The following is a description of a gene set: studied in species Mus musculus Any process that activates or increases the frequency, rate, or extent of a T-helper 1 type immune response. Mouse Gene Set: GOBP_POSITIVE_REGULATION_OF_T_HELPER_1_TYPE_IMMUNE_RESPONSE, and this is the list of marker genes: Xcl1, Il23r, Ripk2, Il18r1, Nlrp10, Slc11a1, Ccr2, Pla2g4a, Il23a, Il18 (NCBI Gene Id 16173), Il27ra (interleukin 27 receptor, alpha), Il12b, Il12rb1, Il1b, Arid5a, Il1r1, Slamf1, Tbx21